Given this list of marker genes Robo3, Foxg1, App, Robo2, Diaph1, Diaph2, Robo1, Gap43, Efnb3, here is a description of the gene set: studied in species Mus musculus The recognition of molecules at a choice point by an axon growth cone; at a choice point the growth cone determines the direction of its future growth. Mouse Gene Set: GOBP_AXON_CHOICE_POINT_RECOGNITION